The following is a description of a gene set: Human Gene Set: HP_CORTICAL_MYOCLONUS Cortical myoclonus mainly affects the distal upper limbs and face, which reflects the largest cortical representations of these body areas. It is often focal, but may be multifocal, bilateral or generalized, as a consequence of intracortical and transcallosal spreading of abnormal activity. It typically occurs on voluntary action and may affect speech and gait. Cortical myoclonic jerks are stimulus sensitive, typically to touch, but sensitivity to visual stimuli is also described. Most patients with cortical myoclonus have both positive myoclonus and NM, occurring either independently or together as a complex of the two kinds of myoclonus. If cortical myoclonus is prolonged and lasts for hours, days or weeks, it is called epilepsia partials continua and is considered to be a rare form of focal epileptic status. Focal cortical myoclonus almost always points to an underlining lesion of the sensori-motor cortex, which produces hyperexcitability (e.g. vascular, inflammatory or neoplastic). studied in species Homo sapiens Cortical myoclonus, and this is the list of marker genes: PGM3, TNRC6A, CASR, GNA11, RAPGEF2